Given this list of marker genes WDR3, UTP18, PES1, WDR36, HEATR1, IMP4, TBL3, RRP7BP, NOC2L, NOP14, PWP2, IMP3, RRP36, KRI1, RRP7A, NOC4L (nucleolar complex associated 4 homolog), UTP6, UTP20, NOL6, SLX9, MPHOSPH10, WDR12, UTP4, NOP9, BOP1, SRFBP1, here is a description of the gene set: A large ribonucleoprotein complex considered to be the earliest preribosomal complex. In S. cerevisiae, it has a size of 90S and consists of the 35S pre-rRNA, early-associating ribosomal proteins most of which are part of the small ribosomal subunit, the U3 snoRNA and associated proteins. Human Gene Set: GOCC_90S_PRERIBOSOME studied in species Homo sapiens